Given this list of marker genes KIF11, RNASEH2B, CPNE8, SLC4A4, DIO2, CASK, PLA2G6, NAF1, IFT81, KIF13B, PHF13, RWDD4, CC2D2B, CORO2B, OPCML (opioid binding protein/cell adhesion molecule like), MTHFD2L, ATP13A2, ENPP2, ANKRD29, PTER, ARHGAP11A, CDH11, CEP152, TCEANC, DSEL, CASS4, MGP, PDSS1, RBMS2, SLC18B1, PMM1, CSGALNACT1, SESTD1, FLRT2, SNRNP48, ATL2, RAP2A, SLC35A2, MPHOSPH9, EPB41L4A, SCAMP1, TREML4, GEN1, PLEKHG1, PTPN21, SPARC, CCDC57, MFAP3L (microfibril associated protein 3 like), MNS1, SLFN12, MID1IP1, EYA4, POLD3 (DNA polymerase delta 3, accessory subunit), GRK3, SCN1B, WDHD1, DENND4C, KIF18A, ZNF35, TIMP3, NFKBIE, KLHL24, DOCK7, CES1, CDK20, RNF185, SEPTIN8, HMGCS1, ZFP41, CCNYL1 (cyclin Y like 1), PBX3, AFF1, NXN, WRN, BEX1, PPM1E, PPP1R3B, LAMA4, DYNC2I2 (NCBI Gene Id 89891), CENPO, STARD4, GPM6B, C9orf40, INSR, ADCY9, BRWD1, FAM221A, GRIA3, IGF2BP2, KLHDC10, SCLT1 (sodium channel and clathrin linker 1), SIK2 (NCBI Gene Id 23235), FZD3, SIVA1, BST1, LMBR1, GPSM2, TMPRSS4, DSN1, NIPAL2, LMLN, SHQ1, LEFTY1, SLC19A2, DHX37, DCTN4, TENM4, KDELR3, STOM, POLR1G (NCBI Gene Id 10849), NUDT12, PDE4D, CYP2J2 (cytochrome P450 family 2 subfamily J member 2), DNAL1, CTSE, DGKG, ANKRD26, SPIB, ESAM, HSPA2, LIG1, PAPSS2, EFS, TMEM26, TMEM87B, NFIB, CCL11, POMGNT2 (NCBI Gene Id 84892), LPAR1, SETD6, F3, MRGPRE, DBNDD2, CDC7, NRCAM, SLC39A8 (NCBI Gene Id 64116), NPNT, NUDT19, NYX, OSBPL1A, BCAT1, GCNT1, CEP83, OIP5, SSBP2, EVC2, GNA14, PCGF3, CPEB1, LARGE1, CSRP2, C8orf34, BRMS1L, CACNB2, ZNF438, NUAK1, STAM, FEM1C, SAMD14, CHEK2, PRR16, LSS, SLC35D1, CCP110, PTPN14, GRHL1, NUP37, PDGFA, ZFP30, TRUB2, PGR, PREP, TEC, YES1, ABTB3, USP6NL, CAMKV, HOXA2, PIK3CD, FHL1, NXPE4 (NCBI Gene Id 54827), SLC25A53, ACER3, EGFLAM, TRAPPC13, EGLN3, TDP2, DCAF12L1, INSIG1, ERLIN1 (ER lipid raft associated 1), CC2D2A, MYB, FAM217B, TBL2, TIRAP, SLIT2, KIF20B (NCBI Gene Id 9585), CLEC10A, CREB3L2, SERPING1, here is a description of the gene set: from publication Borjesson DL, Kobayashi SD, Whitney AR, Voyich JM, Argue CM, Deleo FR (PMID 15879137) Human Gene Set: GSE2405_HEAT_KILLED_VS_LIVE_A_PHAGOCYTOPHILUM_STIM_NEUTROPHIL_9H_DN Polymorphonuclear leukocytes (PMNs) were obtained from healthy individuals in accordance with protocols approved by the Institutional Review Board for Human Subjects at the University of Minnesota and the National Institute of Allergy and Infectious Diseases. PMNs (107) were combined on ice with live S. aureus (108) or with live or heat-killed A. phagocytophilum (bacteria isolated from 5x106 infected HL60 cells for a ratio of 1 infected HL60 cell: 2 PMNs, ~ 5-20 A. phagocytophilum: PMN) in wells of a 12-well tissue culture plate (pre-coated with 20% autologous normal human serum). Unstimulated control assays received either buffer (for S. aureus comparisons) or clarified HL60 lysate (for A. phagocytophilum comparisons). Plates were centrifuged at 350 x g for 8 min at 4oC to synchronize phagocytosis and incubated at 37 deg. C in a CO2 incubator for the indicated times. At the indicated times, tissue culture medium was aspirated from the plate and PMNs were lysed directly with RLT buffer (Qiagen, Valencia, CA). Purification of PMN RNA and subsequent preparation of labeled cRNA target was performed as described in Methods. Labeling of samples, hybridization of cRNA with HU133A oligonucleotide arrays (Affymetrix, Santa Clara, CA), and scanning were performed according to standard Affymetrix protocols ( http://www.affymetrix.com/pdf/expression_manual.pdf ). Experiments were performed in triplicate, using PMNs from three healthy individuals for each treatment. studied in species Homo sapiens Genes down-regulated in polymorphonuclear leukocytes (9h) infection by A. phagocytophilum: heat killed versus live bacteria.